The following is a description of a gene set: Genes upregulated in subsets of cells of a given type within various tumors Human Gene Set: GAVISH_3CA_MALIGNANT_METAPROGRAM_30_PDAC_CLASSICAL In this study, an extensive analysis was conducted to define meta-programs (MPs) capturing intra-tumor heterogeneity across a spectrum of tumor types. The approach utilized non-negative matrix factorization (NMF) to analyze each cell type separately within individual tumor samples. This involved the analysis of malignant cells, macrophages, fibroblasts, endothelial cells, epithelial cells, T-cells, and B-cells. NMF was executed with varying parameter values (K=4, 5, 6, 7, 8, 9), thereby generating 39 programs for each cell type per sample. Each NMF program was summarized by the top genes based on NMF coefficients.\nRobust MPs were then delineated for each cell type using a set of stringent criteria, including recurrence within the same tumor, similarity to programs in other tumors, and non-redundancy within a tumor. Subsequently, these robust NMF programs were clustered (per cell type) based on Jaccard similarity, leading to the identification of MPs associated with each cell type.\nTo enhance the quality of the MPs, a refinement steps were undertaken, involving the removal of MPs suspected of reflecting low-quality data (with an overrepresentation of ribosomal proteins or mitochondrial-encoded genes), single-study inclusion, or similarity to miss-annotated cell types. studied in species Homo sapiens from publication Gavish A, Tyler M, Greenwald AC, Hoefflin R, Simkin D, Tschernichovsky R, Galili Darnell N, Somech E, Barbolin C, Antman T, Kovarsky D, Barrett T, Gonzalez Castro LN, Halder D, Chanoch-Myers R, Laffy J, Mints M, Wider A, Tal R, Spitzer A, Hara T, Raitses-Gurevich M, Stossel C, Golan T, Tirosh A, Suvà ML, Puram SV, Tirosh I (PMID 37258682), and this is the list of marker genes: SLC40A1, LYZ, GPX2, OLFM4, CXCL17, VSIG1, DUOXA2, SLC44A4, PSCA, MUC5B, TCN1, PDZK1IP1, PHGR1, MUC5AC, CDH17, TSPAN8, TFF2, CLDN18, TFF1, PDE4C, AGR2, TSPAN1, CEACAM1, CTSE, CEACAM6, TFF3, TM4SF4 (transmembrane 4 L six family member 4), PLA2G10, ANXA10, SPINK1, FXYD3, LGALS4, PIGR, AGR3, FAM3D, HPGD, GCNT3, VSIG2, MUC13, LINC01133, DUOX2, PLAC8, AKR7A3 (aldo-keto reductase family 7 member A3), CEACAM7, CEACAM5, ISG20, REG4, CA2, MUCL3, CES2